The following is a description of a gene set: species: Mus musculus Mouse Gene Set: REACTOME_SYNTHESIS_OF_GDP_MANNOSE Synthesis of GDP-mannose, and this is the list of marker genes: Gmppb, Mpi, Hk1, Pmm1, Gmppa, Pmm2